The following is a description of a gene set: Genes predicted to be targets of miRBase v22 microRNA mmu_miR_7056_5p in miRDB v6.0 with MirTarget v4 prediction scores > 80 (high confidence targets). Mouse Gene Set: MIR_7056_5P species: Mus musculus from publication Chen Y, Wang X (PMID 31504780), and this is the list of marker genes: Retreg3, Cbfa2t2, Nlk, Txnl4b, Foxp3, Bap1, BC035044, Cdk5 (cyclin dependent kinase 5), Slc49a3, Dffa, Prlr, Mrps18a, Sidt1, Ak1 (adenylate kinase 1), Adra2a, Iqsec2, H2bc22, Pea15a, Swsap1, Adamts9, Pcdh20, Ap1s1, Pxk, Wnt7b, Pdgfb, Trp53i11, Trmt2b, Amdhd1, Sptb, Coa4, Dcun1d2, Zc3h4, Lims1, Nkain1, Pde6a, Ccser2, Agtr1a, Mob3a, Prps2, Xirp1, Git2, Sec23b, Cemip, Fam133b, Rundc1, Tmem63c, Serpina1f, Fasn, Acaca, Pax7, Vstm2b, Kpna3, Xkr4, Flt4 (FMS-like tyrosine kinase 4), Lamc3, Zdhhc8, Mlph, Ntsr1, Stmn2, Pskh1, Synj2bp, Tmem51, Nkain3, Chd3, Ush1g, B3gnt2, Krtap5-5, Stag2, Tbkbp1, Midn, Rps23rg1, Stambp, Tead3, Col1a2, St7l, Utp23, Lamc1, Usb1, 2410004P03Rik, Rsph4a, Kars1, Hivep3, Garem1, Pakap, Ankrd40, Chmp1b2, Ywhab, Nfat5, Prkdc, Camk1d, Lrrc73, Garin2, Peg10, Nfatc3, Fbxl14